Given this list of marker genes Cacna1h, Plcb1, Glra1, Plb1, Fam170b, Spink13, Spink1, Iqcf1, Zp3, Prss37, Hvcn1, Crisp4, B4galt1, Pla2g10, Ccdc87, Pkdrej, here is a description of the gene set: studied in species Mus musculus Mouse Gene Set: GOBP_REGULATION_OF_ACROSOME_REACTION Any process that modulates the frequency, rate or extent of the acrosome reaction.